Given this list of marker genes ASPH, CTNNA1, QPRT, VANGL1, HOXA10, BIK (BCL2 interacting killer), TGIF2, SNX10, UNC13B, CDC42BPB, FTO, PPP1R26, WDFY3, HOXA2, SCHIP1, SMPDL3A, PTX3 (NCBI Gene Id 7129), HOXB2, HOXA11, CAVIN2, LTB, PDGFD, CPA3, FBXO28, RASGRP3, H2BC12L, TRIM32, RPS6KC1, SGPL1 (sphingosine-1-phosphate lyase 1), HOXA4, CORO1B, STRN3, RTL8A, ARHGAP25, PCDH9, WDR91, HOXA6 (homeobox A6), IRX5, BCL10, TMBIM1, PLS1, NAB2, BEX3, HOXA1, MEIS1, FAM110B, DRAM1 (DNA damage regulated autophagy modulator 1), RTL8C, ADGRE1, MSMO1, LMNA, COCH, GATA2, HOXB6, PSEN1, FOXC1, RAB38, KRT18, HOXB5, GSTM3, RAB13, KCNK5, H2BC21, ADAMDEC1, EPB41L3, LAPTM4B, HNMT, GRB10, SC5D, ATP6V1B2, SCYL3, MTARC2 (mitochondrial amidoxime reducing component 2), IP6K1, SLC29A3, ACVR1B, HOXB3, SEMA4C, TOM1L1, HOXA7, H2BC4 (NCBI Gene Id 8347), AQP3, TBL2, LTBP1, DEFB1, DSC2, ICA1, CFH, MACO1, LAMB2, HOXB7, TCEAL9, SNX11, TANK, LUM, HOXA9, ADAM17, F13A1, IGHA1, ABCC6, SELENOP, IGFBP2, SNCAIP, ITGA5, ADO, HOXA5, HOXB9, UGGT2, COL4A5, FZD7, RRBP1, CTNND1, ECHDC2, NKX3-1, JAG1, MMP2, ARHGAP22, CLU, WT1, HMGCS1, TLR4, SPATA6, H2BC6, CHD7, DLG5, ZCCHC2, MTMR9, ACVR1, C3AR1, NFE2L3, H2AC18, AGXT, PIEZO2, SLC24A3, PLPPR3, SMC4, ZNF580, NAALADL1, LRIG1, DPYSL3, PBX3, here is a description of the gene set: species: Homo sapiens Human Gene Set: ALCALAY_AML_BY_NPM1_LOCALIZATION_UP Genes up-regulated in acute myeloid leukemia (AML) with respect to cellular localization of NPM1: cytoplasmic vs. nucleolar. Approximately one third of acute myeloid leukemias (AMLs) are characterized by aberrant cytoplasmic localization of nucleophosmin (NPMc+ AML), consequent to mutations in the NPM putative nucleolar localization signal. These events are mutually exclusive with the major AML-associated chromosomal rearrangements, and are frequently associated with normal karyotype, FLT3 mutations, and multilineage involvement. We report the gene expression profiles of 78 de novo AMLs (72 with normal karyotype; 6 without major chromosomal abnormalities) that were characterized for the subcellular localization and mutation status of NPM. Unsupervised clustering clearly separated NPMc+ from NPMc- AMLs, regardless of the presence of FLT3 mutations or non-major chromosomal rearrangements, supporting the concept that NPMc+ AML represents a distinct entity. The molecular signature of NPMc+ AML includes up-regulation of several genes putatively involved in the maintenance of a stem-cell phenotype, suggesting that NPMc+ AML may derive from a multipotent hematopoietic progenitor. from publication Alcalay M, Tiacci E, Bergomas R, Bigerna B, Venturini E, Minardi SP, Meani N, Diverio D, Bernard L, Tizzoni L, Volorio S, Luzi L, Colombo E, Lo Coco F, Mecucci C, Falini B, Pelicci PG (PMID 15831697)